Given this list of marker genes TREM2, PRKCI, AKAP12, CERS6, GAS6, CCL2, PRKCA, DLL1, RAD21, PRKCH, PRKCD, TRAF2, here is a description of the gene set: Human Gene Set: GOBP_REGULATION_OF_GLIAL_CELL_APOPTOTIC_PROCESS studied in species Homo sapiens Any process that modulates the frequency, rate, or extent of glial cell apoptotic process.